The following is a description of a gene set: species: Homo sapiens Any process that activates or increases the frequency, rate or extent of vasoconstriction. Human Gene Set: GOBP_POSITIVE_REGULATION_OF_VASOCONSTRICTION, and this is the list of marker genes: ADRA1A, GJA5, TBXAS1, ADD3, HRH1, ADRA1D, MIR21, AVPR2, CAV1, ABL1, RHOA, FGB, DBH, FGA, FAAH, SMTNL1, CASR, HTR2A, CD38, F2R, TRPM4, AVPR1B, AVPR1A, OXTR, AVP, TBXA2R, HRH2, TACR1 (NCBI Gene Id 6869), FGG